The following is a description of a gene set: Human Gene Set: REACTOME_ECM_PROTEOGLYCANS ECM proteoglycans studied in species Homo sapiens, and this is the list of marker genes: DAG1, BCAN, FMOD, MATN4, PTPRS, DMP1, COL9A2, LUM, TGFB3, NCAM1, BGN (biglycan), COL6A1, ITGB1, COL5A1, LAMC1, COL4A4, VCAN, COL4A3, LAMA2, MUSK, TNR (tenascin R), COL6A6, SERPINE1, COL5A3, TNN, APP, HSPG2, ITGAV, ITGA2B, ITGB3, HAPLN1, COL4A5, COL4A2 (collagen type IV alpha 2 chain), TGFB1, COL6A5, AGRN, LRP4, COL4A6, TGFB2, VTN, TNXB, LAMB2, TNC, COL1A1, NCAN, ITGA7, ITGA2, ITGB5, LAMA5, LAMA3 (NCBI Gene Id 3909), DCN, COL4A1, LAMA4, SPARC, COL2A1 (collagen type II alpha 1 chain, NCBI Gene Id 444981), MATN3, FN1, COL6A2, LAMB1 (laminin subunit beta 1), ACAN, COL9A3, COL6A3, COL3A1, ASPN, COL5A2, DSPP, LAMA1, COL9A1, ITGAX, COMP, ITGA9 (integrin subunit alpha 9), ITGB6, IBSP, COL1A2, ITGA8, MATN1